The following is a description of a gene set: species: Homo sapiens While the p53 tumor suppressor protein (TP53) is known to inhibit cell growth by inducing apoptosis, senescence and cell cycle arrest, recent studies have found that p53 is also able to influence cell metabolism to prevent tumor development. TP53 regulates transcription of many genes involved in the metabolism of carbohydrates, nucleotides and amino acids, protein synthesis and aerobic respiration.<p>TP53 stimulates transcription of TIGAR, a D-fructose 2,6-bisphosphatase. TIGAR activity decreases glycolytic rate and lowers ROS (reactive oxygen species) levels in cells. TP53 may also negatively regulate the rate of glycolysis by inhibiting the expression of glucose transporters GLUT1, GLUT3 and GLUT4.<p>TP53 negatively regulates several key points in PI3K/AKT signaling and downstream mTOR signaling, decreasing the rate of protein synthesis and, hence, cellular growth. TP53 directly stimulates transcription of the tumor suppressor PTEN, which acts to inhibit PI3K-mediated activation of AKT. TP53 stimulates transcription of sestrin genes, SESN1, SESN2, and SESN3. One of sestrin functions may be to reduce and reactivate overoxidized peroxiredoxin PRDX1, thereby reducing ROS levels. Another function of sestrins is to bind the activated AMPK complex and protect it from AKT-mediated inactivation. By enhancing AMPK activity, sestrins negatively regulate mTOR signaling. The expression of DDIT4 (REDD1), another negative regulator of mTOR signaling, is directly stimulated by TP63 and TP53. DDIT4 prevents AKT-mediated inactivation of TSC1:TSC2 complex, thus inhibiting mTOR cascade. TP53 may also be involved, directly or indirectly, in regulation of expression of other participants of PI3K/AKT/mTOR signaling, such as PIK3CA, TSC2 and AMPKB. <p>TP53 regulates mitochondrial metabolism through several routes. TP53 stimulates transcription of SCO2 gene, which encodes a mitochondrial cytochrome c oxidase assembly protein. TP53 stimulates transcription of RRM2B gene, which encodes a subunit of the ribonucleotide reductase complex, responsible for the conversion of ribonucleotides to deoxyribonucleotides and essential for the maintenance of mitochondrial DNA content in the cell. TP53 also transactivates mitochondrial transcription factor A (TFAM), a nuclear-encoded gene important for mitochondrial DNA (mtDNA) transcription and maintenance. Finally, TP53 stimulates transcription of the mitochondrial glutaminase GLS2, leading to increased mitochondrial respiration rate and reduced ROS levels. <p>The great majority of tumor cells generate energy through aerobic glycolysis, rather than the much more efficient aerobic mitochondrial respiration, and this metabolic change is known as the Warburg effect. Since the majority of tumor cells have impaired TP53 function, and TP53 regulates a number of genes involved in glycolysis and mitochondrial respiration, it is likely that TP53 inactivation plays an important role in the metabolic derangement of cancer cells such as the Warburg effect and the concomitant increased tumorigenicity. On the other hand, some mutations of TP53 in Li-Fraumeni syndrome may result in the retention of its wild-type metabolic activities while losing cell cycle and apoptosis functions. Consistent with such human data, some mutations of p53, unlike p53 null state, retain the ability to regulate energy metabolism while being inactive in regulating its classic gene targets involved in cell cycle, apoptosis and senescence. Retention of metabolic and antioxidant functions of p53 protects p53 mutant mice from early onset tumorigenesis. Reactome Pathway: TP53 Regulates Metabolic Genes part of: Transcriptional Regulation by TP53, and this is the list of marker genes: AKT2, PRKAG1, COX6B2 (NCBI Gene Id 125965), TP63, PRDX1, MLST8, SLC38A9 (NCBI Gene Id 153129), PRKAA2, GLS, COXFA4, COX6C, YWHAB, COX5B, COX5A, RPTOR, LAMTOR4, TNRC6C, TSC1, TSC2, LAMTOR5, COX7A2, AGO1, RRAGC, AGO2, PRKAA1, LAMTOR1, GPI, MOV10, TXN, COX8A, LAMTOR2, GLS2, MT-CO3, RRAGA, MT-CO2, COX4I1, SESN2, TIGAR, COX4I2, TNRC6B, DDIT4, GSR, COX6A2, AKT3, HIGD1C, COX6B1, RRM2B, COX7A2L, PRDX5, COX7B, CYCS (NCBI Gene Id 54205), YWHAG, SESN1, LAMTOR3, MTOR, COX7A1, PRKAB2, YWHAE (NCBI Gene Id 7531), PRDX2, SCO2 (synthesis of cytochrome C oxidase 2), AKT1, COX6A1, YWHAH, TXNRD1, YWHAZ, TNRC6A, PRKAB1, RRAGB, YWHAQ, TP53, RRAGD, G6PD, SFN, MIR26A2, AGO4, GPX2, MIR26A1, PRKAG2, PTEN, SESN3, COX8C, RHEB, PRKAG3, AGO3, COX7C, MT-CO1